Given this list of marker genes Ctsg, Pla2g5 (NCBI Gene Id 18784), Tigit, Cbfb, Spi1, Havcr2, Adtrp, Il2ra, Lilrb4a, Cd44, Ptpn22, Zbtb7b, Ildr2, Cd69, Gtpbp4, Pla2g2f, H2-T23, Ceacam1, Akna, Lgals9, Tnr, Ptpn2, Prdx2, Dlg5, Podxl, Slc4a2, Klf4, Wnt1, Rc3h1, Runx3, Spint2, Ccm2l, Gimap5, Map2k5, C1qtnf1, Tmem131l, Map2k1, Pik3r1, Casp3, Arg2, Cdkn2a, Ndfip1, H2-Aa, Ccl25, Nrarp, Adora2a, Myadm, Lrrc32, Jak3, Pdcd1 (programmed cell death 1), Socs5, Tspan32, Anxa1, Cd80, Muc21, Zc3h12a, Crtam, Sftpd, Apoa1, Shh, Abl2, Ptpn6, Cd37, Dusp22, Fgl1, Scgb1a1 (NCBI Gene Id 22287), Zc3h8, Prnp, Ppm1f, Socs1, Abl1, Prkar1a, Peli1, Hlx (H2.0-like homeobox, NCBI Gene Id 15284), Tgfb1, Cd24a, Ripor2, Tnfaip3, Nfkbid, Il4ra, Ptk2, Ass1, Lgals1, Tnfsf18, Btn2a2, Lgals3, Ythdf2, Mdk, Tbx21, Rdx, Cd74 (CD74 antigen (invariant polypeptide of major histocompatibility complex, class II antigen-associated)), Clec4g, Il20rb, Ufl1, Cd274, Mad2l2, Bmp6, Alox12, Itch, Adam8, Tnfaip8l2, Prkg1, Xcl1, Tnfrsf21, Glmn, H2-M3, Rag2, Ido1, Lag3, Trpv4 (transient receptor potential cation channel, subfamily V, member 4), Il2, Smad7, Ccl21b, Cd86, Jag1, Wnk1, Notch1, Hmgb1, Irf1, Dapl1, Mia3, Twsg1, Rgcc, Specc1l, Runx1, Ihh, Zfp608, Tmx1, Btla, Tarm1, Ccl28, Epcam, Gimap3, Loxl3, Hfe, Abca12, Bmp2, Zfp703, Bcl6, Ccl21d, Ccl21a (NCBI Gene Id 18829), Swap70, Pla2g2a, Dlg1, Cxcl12, Prkcd, Erbb2, Il10 (NCBI Gene Id 16153), Ctla4, Pde5a, Slfn1, Muc4, Zfp35, Cd9, Foxp3 (forkhead box P3), Fgl2, Cdsn (corneodesmosin), Pten, Adipoq (NCBI Gene Id 11450), Bmp4, Cd300a, Pf4, Mbp, Mettl3, Arg1, Vsig4, Ccl21f, Pag1, Epb41l5, Il4, Cdh1, Akt1, Sdc4, Il1rn, Gli3, B4galnt2 (NCBI Gene Id 14422), Laptm5, Mapk7, Foxj1, Nf2, Ifnb1, Cebpb, Vsir, Marchf7, Pawr, Dusp3, Mad1l1, Ascl2, Notch4, Nexmif, Adamts18, Gnrh1, Ccl21e, Tnfrsf14, Vegfa, Gstp1, Ppara, Serpine2, Pdcd1lg2, Ubash3b, Tsc2, Tnfsf4, Spn, Lilrb4b, Socs6, Lax1, Scrib, Cd276, Rc3h2, Il4i1, Pla2g2d, Cblb, Vtcn1, Zc3h12d, Jak2, Gpnmb, Dtx1, Hspb1 (NCBI Gene Id 15507), Sh2b3, here is a description of the gene set: Any process that stops, prevents or reduces the rate or extent of cell adhesion to another cell. studied in species Mus musculus Mouse Gene Set: GOBP_NEGATIVE_REGULATION_OF_CELL_CELL_ADHESION